The following is a description of a gene set: Differentially expressed genes of CD11b+Gr-1+ immature myeloid cells (IMCs) in the bone marrow and colonic tumor setting of histidine decarboxylase (HDC)-KO mice were examined by microarray (Affymetrix Mouse 430.2 array). Myeloid differentiation-related candidate genes were sought to be isolated and functionally studied. Human Gene Set: GSE23502_BM_VS_COLON_TUMOR_MYELOID_DERIVED_SUPPRESSOR_CELL_DN Genes down-regulated in myeloid-derived suppressor cells: bone marrow versus colon tumor. studied in species Homo sapiens from publication Yang XD, Ai W, Asfaha S, Bhagat G, Friedman RA, Jin G, Park H, Shykind B, Diacovo TG, Falus A, Wang TC (PMID 21170045), and this is the list of marker genes: IGLC7, BUB1, PKIB, CCNT2, KLHL6, CELSR2, SNHG8, GPR174, TMEM131L, IRF2BPL, ADRB2, H2BC13, MAP7, DHFR, OGFRL1, ZRANB2, KMO, FCRL1, PTCD3, ATAD5, PROM1, MYB, MTF2, NCAPG, HMGB2, CCDC14, HAT1, RAPGEF4, SHISA5, ARPC5L, TASOR, AKT3, ZNF207, TMEM108, HLA-DOB, DDX3Y, HPS3, CHTOP, LAX1, PTPN6, CLK4, FAM76B, BACH2, FRMD4A, TRIM21, HLA-G, TNFRSF13C, HHEX, CADM1, RBM39, DOCK11, NCK2, PTK2B, DYRK2, ZNF292, EML4, PRR11, CDC42EP3, C15orf61, AKAP12, PCLAF, HERC4, ELK3, RICTOR, PDS5B, TLR1, XCL1, SLF1 (SMC5-SMC6 complex localization factor 1), GPR155, NR2C2, CHCHD10, ST8SIA4, PAG1, NLRC3, ZUP1, STK26, DOCK10, MYL4, KDM5D, TEX9, SEMA4B, MBD4, LMO2, LDLRAD3, FLI1, FBXO33, MDC1, PRP4K, CCNH, DUSP2, SRSF1, DZIP3, TMF1, ARID1A, CR2, RASGRP3, SORL1, CENPK, BCL11A, ACSF2, RNASE6, ECT2, CPSF6, TOX, ARMC9, CCDC77, MND1, CCDC88A, PCP4, SESN1, LAPTM5, NXPE4, RETREG1, ARID1B, EVI2B, SLC4A7, LPAR6, TBC1D8, TLK1, CDK5R1, DUSP6, SLAMF7, GCSAM, TNFRSF21, B3GNT5, FOXK1, TRAPPC8, CBX3, KRR1, VANGL2, RSRP1, LRRK2 (NCBI Gene Id 399472), TMPO, ZNF608, GAS2L3, BUB1B, LRATD2, ULBP1 (UL16 binding protein 1), RFX7, FCER2, DDX25, BMF, ZNF318, UBLCP1, MORC3, TIAL1, FCHSD2, SPRY2 (sprouty RTK signaling antagonist 2), BRWD1, ENTPD5, RGS2, FH, SLC16A4, HPGD, CD72, TSPAN8, RPRD1A, ATP8A1, ZFC3H1, SMCHD1, FYN, SAMTOR, RNF145, RRM2, TNKS (NCBI Gene Id 8658), RFC1, CDKN1B, SELL, VPREB3, RFX5, CCNG2, TM6SF1, FBXL14, TAX1BP1 (Tax1 binding protein 1), TXNIP, CDCA2, CARD6, TLR3, KLRD1, SPIC, KLHL42, RRAS2, JCHAIN, LIMD2, VCAM1, NEIL3, CD200, ICOSLG, MKI67 (NCBI Gene Id 4288), TRIM59, GCNT1 (NCBI Gene Id 2650), TFDP2, BMP2K, CD1D, PXDC1, DDX17, UGP2, SNX13, PDE4B, BTLA